The following is a description of a gene set: Human Gene Set: MIR133A_5P studied in species Homo sapiens Genes predicted to be targets of miRBase v22 microRNA hsa-miR-133a-5p in miRDB v6.0 with MirTarget v4 prediction scores > 80 (high confidence targets). from publication Chen Y, Wang X (PMID 31504780), and this is the list of marker genes: PACSIN2, CSRP2, NOVA1, PARP8, PIK3R1, CLVS1, AMMECR1, ACTR8, MAPK6, USP49, SCN3A, COBLL1, TCEAL5, H2AX, KDM5A, SCRN1, AMBN, RNF38, BAZ1B, PPIP5K1 (NCBI Gene Id 9677), AGO4, DHTKD1, CEP350, KLF11, NEUROD1, EIF3J, CASP3, DESI2, GNG2, PCGF3, MAN2A1, CLIP1, CNBD1, CUL5, SIM1, LIN9, PCNX1, EID1, RASSF8, VANGL1, PDIK1L, CYFIP1, CAPS2, NSMF, GBF1, P2RX7, PTPN4, TRPC7, CLOCK (clock circadian regulator), LAPTM4A, GPHN, ATG5, ZIC2, TNRC6B, PPARD, ARHGAP6, PTGFRN, ATP8A1, ATP11C, DGKE, ERCC4, FEM1C, PHF2, FRMD5, TMEM182 (NCBI Gene Id 130827), RB1CC1, SNAP25, C11orf91, EN2, ZBTB6, IPO8, FYCO1, EPHA7, ZRANB1, ST6GALNAC4, STAG1, VIM, PPT1, RNF19A, SLX4, FERMT2, LZTS3, SENP7, TMED5, NCBP3, HIF1A, ZFPM2, ACVR2B, KLHL18, RARA, GRSF1, TCEAL8, DMXL2, STRBP, BRI3BP, XPNPEP3, GPBP1, GAL3ST3, PPP1R42, PHF5A, SEZ6L2, RIMS4, RORA, UTP14C, DEK, FAM219B, ARRDC3, RPRD1B (NCBI Gene Id 58537), LRRTM4, HECTD2, GPATCH8, ZHX2, PIF1, EFR3A, APPBP2 (amyloid beta precursor protein binding protein 2), BEX2, MAST4 (NCBI Gene Id 375449), RELN, SERTAD4, NFIB, RTN1, VEZF1, DLK1, RCN2, TMEM167A, KLF12, ACADSB, ULBP2, KMT5B, DNA2, L3MBTL3, DZIP3, BEX1, RIMS2